Given this list of marker genes Cdkn2a, Limk1, Rps20, Rpl37rt, Rpl23, Rpl37, Rpl11, Rps15, Rps7, Htra2, Rpl5, Fbxo5, here is a description of the gene set: Binds to and stops, prevents or reduces the activity of a ubiquitin ligase. Mouse Gene Set: GOMF_UBIQUITIN_LIGASE_INHIBITOR_ACTIVITY species: Mus musculus